The following is a description of a gene set: studied in species Homo sapiens Human Gene Set: HP_FACIAL_EDEMA Facial edema, and this is the list of marker genes: ANLN, NUP133, PSPH, CCBE1, PROP1, RBMX, NKX2-5, GPR101, NPHS1, KCTD1, CLIP2, SLC29A3 (solute carrier family 29 member 3), RFC2, COQ8B, LIMK1, ARHGAP24, COL5A2, KPTN, NUP160, GTF2I, ANGPT1, NPHS2, POU4F1 (POU class 4 homeobox 1), PTPRO, SLC26A4, CRB2, FRMD4A, NUP107, TGFBI, SLC35C1, GSN, IYD, HS3ST6, NUP85, PRTN3, KNG1, STX1A, HESX1, XPNPEP2, FBXO11, SPTBN1, PSMB4, LYN, HAVCR2, PLG (plasminogen), MAGI2, COL1A1, CTLA4 (NCBI Gene Id 3411), MYD88, TBC1D8B, BAZ1B, LHX3, POMP, RIN2, ELN, PLCE1 (phospholipase C epsilon 1), EPHB4, EIF4H, KAT6A, COL5A1, BUD23, MED12L, FKBP6, DAAM2, COL4A3, SUMF1, TSHR, CAMTA1, ACTG1, DNAJC30 (DnaJ heat shock protein family (Hsp40) member C30), DUOX2, PEX2, ACTN4, DHX30, LTBP4, CD2AP, INF2, FOXE1, FOXG1, ARHGDIA, NKX2-1, ANKFY1, NEU1, TRPC6, ANAPC1, METTL27, TMEM270 (transmembrane protein 270), SERPING1, APOL1, ZNHIT3, PEX5, SOX18, PAX2, DUOXA2, GTF2IRD2, AIP, TG, PIK3CD, MYO1E, NCF1, IGSF3, NUP37, TSHB (thyroid stimulating hormone subunit beta), TBL2, ALB, PTPN22, SNX14, GNPTAB, VPS37D, CDH11 (cadherin 11, NCBI Gene Id 1009), POU1F1, ADAMTS2, EMP2, LHX4, GTF2IRD1, NUP93, RECQL4, GAPVD1, HLA-DPB1, EFEMP1, ACTB, MYOF, SHANK3, SLC5A5, KNSTRN (kinetochore localized astrin (SPAG5) binding protein), PAX8, PIEZO1, HLA-DPA1, TNFRSF1A (NCBI Gene Id 8077), F12, TPO, NUP205, ANTXR1, WT1